The following is a description of a gene set: species: Homo sapiens Top 50 down-regulated markers distinguishing diffuse large B-cell lymphoma (DLBCL) from follicular lymphoma (FL) samples. Human Gene Set: SHIPP_DLBCL_VS_FOLLICULAR_LYMPHOMA_DN Diffuse large B-cell lymphoma (DLBCL), the most common lymphoid malignancy in adults, is curable in less than 50% of patients. Prognostic models based on pre-treatment characteristics, such as the International Prognostic Index (IPI), are currently used to predict outcome in DLBCL. However, clinical outcome models identify neither the molecular basis of clinical heterogeneity, nor specific therapeutic targets. We analyzed the expression of genes in diagnostic tumor specimens from DLBCL patients who received cyclophosphamide, adriamycin, vincristine and prednisone (CHOP)-based chemotherapy, and applied a supervised learning prediction method to identify cured versus fatal or refractory disease. The algorithm classified two categories of patients with very different five-year overall survival rates (70% versus 12%). The model also effectively delineated patients within specific IPI risk categories who were likely to be cured or to die of their disease. Genes implicated in DLBCL outcome included some that regulate responses to B-cell-receptor signaling, critical serine/threonine phosphorylation pathways and apoptosis. Our data indicate that supervised learning classification techniques can predict outcome in DLBCL and identify rational targets for intervention. from publication Shipp MA, Ross KN, Tamayo P, Weng AP, Kutok JL, Aguiar RC, Gaasenbeek M, Angelo M, Reich M, Pinkus GS, Ray TS, Koval MA, Last KW, Norton A, Lister TA, Mesirov J, Neuberg DS, Lander ES, Aster JC, Golub TR (PMID 11786909), and this is the list of marker genes: ATRX, CD3E, CD101, RHOH (ras homolog family member H), RAPSN, ST8SIA1, ZNF141, GPR18, LY9 (lymphocyte antigen 9), CD3D, PIK3IP1, PDCD1, CSN2, TCF20, CIRBP, HES1, TRAF5, ANK2, CCL21, TCEAL1, CLU, SELENOP, PMCH, CSRP2, POU6F1, GLIPR1, HSPA1L, DNASE1L3, STX16, TXK, ITGA4, TSC22D3, ACKR1, CCL14, TNFRSF25, CD40LG, TRIB2, MEF2C, TXNIP, ZMYND11, TRBC1, CD180, CD69, WWP1, INPP1